Given this list of marker genes BSG, TFDP1, BLVRB, GLRX5 (NCBI Gene Id 51218), CLIC2, PNP, DCAF11, UBE2O, CA2, SLC12A3, HMBS (NCBI Gene Id 5448), MKRN1, MPP1, ERMAP (erythroblast membrane associated protein (Scianna blood group), NCBI Gene Id 6306), UROD, GYPB, SLC30A1, SPTA1, TRAK2, RHAG, H1-0 (H1.0 linker histone), RBX1, GYPA, EIF2AK1, FBXO9, NUDT4, PPOX, FBXO7, GYPC, BNIP3L, RHD, ALAS2, ANK1, AHSP, SMOX, SELENBP1, GYPE, RPIA, EPB42, FOXO3, FECH, RHCE, MARK3, TAL1, EIF1AY, NFE2, TSPAN5 (tetraspanin 5), RAD23A, ACSL6, H4C3, MARCHF8, SNCA, ISCA1, RANBP10 (NCBI Gene Id 57610), ALAD, SLC22A4, TOP1, CDC27, GCLC, TSPO2, TMCC2, MAP2K3, HBQ1, SPTB, OSBP2, XPO7, TRIM10 (tripartite motif containing 10), SLC4A1, here is a description of the gene set: Neighborhood of BNIP3L studied in species Homo sapiens Neighborhood of BNIP3L BCL2/adenovirus E1B 19kDa interacting protein 3-like in the GNF2 expression compendium Human Gene Set: GNF2_BNIP3L